Given this list of marker genes PDE7B, PPIAL4E, NBPF20, A1CF, TUB (NCBI Gene Id 7275), HSBP1, PCDHB13, ARL14, PTPRK, NBPF15, PHF21A, ZBTB40, ATRNL1, HRH1, DNAJC5G, NTRK2, PLEKHA8, SOS1, PPIAL4D, GTF2I (NCBI Gene Id 90875), CADPS, EIF3A, CEACAM19, MUC7, STAG2, ZBTB6, KCTD15, EXTL3, PPIAL4C, BTBD2, SRGAP3, SCNM1, NMRK1, ZMIZ1, TGOLN2, RAB43, NBPF9, IMPA1, MYO1B, NPTXR, CCDC92, PLCB4, HYCC2, NBPF14, KCNMB1, PLEK2 (pleckstrin 2), FAM168B, SLCO2A1, NWD2, SOX6 (NCBI Gene Id 84363), CWC27, NKAIN2, SORCS3, RDH12, CNKSR2, MSTN, HEY2, here is a description of the gene set: Human Gene Set: MIR3622B_5P from publication Chen Y, Wang X (PMID 31504780) studied in species Homo sapiens Genes predicted to be targets of miRBase v22 microRNA hsa-miR-3622b-5p in miRDB v6.0 with MirTarget v4 prediction scores > 80 (high confidence targets).